The following is a description of a gene set: studied in species Homo sapiens Genes up-regulated in comparison of untreated CD4 T cells versus those treated with TGFB3, IL6 and IL32A. TGF-beta3 produced by developing Th17 cells induces highly pathogenic T cells that are functionally and molecularly distinct from TGF-beta1-induced Th17 cells. The microarray data represent a distinct molecular signature for pathogenic versus non-pathogenic Th17 cells. Human Gene Set: GSE39820_CTRL_VS_TGFBETA3_IL6_IL23A_CD4_TCELL_UP from publication Lee Y, Awasthi A, Yosef N, Quintana FJ, Xiao S, Peters A, Wu C, Kleinewietfeld M, Kunder S, Hafler DA, Sobel RA, Regev A, Kuchroo VK (PMID 22961052), and this is the list of marker genes: ATAD5, NUP160, SEC11C, RBMXL1, ZFYVE27, HOOK1, OVGP1, HNRNPAB, TNRC6A, ZNF436, ZNF638, DCAF17, REV1, KCNK10, METTL25, PALS1, WDHD1, ERCC6L (ERCC excision repair 6 like, spindle assembly checkpoint helicase), C5orf22, TCERG1, DNAJA1, OXSM, RIMOC1, ZBTB34, ERGIC1 (endoplasmic reticulum-golgi intermediate compartment 1), PLCXD2, DEK, BAG4, ZNF565, PPP2R1B, CD1D, CENPE, COX15, PTS, SF3B2 (NCBI Gene Id 170474), LGALS7, TP53BP1, FEM1B, KCTD3, LRRC40, CD83, DVL1, HAUS6, PTDSS1, XIAP, PWP1, MID1, ATP11C, TAF1D, MOSMO, KDM2B, HSPA8, NEK9, L2HGDH, RBBP4 (RB binding protein 4, chromatin remodeling factor), PUM2, CCDC77, GPATCH4, COQ2, INTS7, METTL25B, TRIM33, ESYT2, PRKCE, PPWD1, ARMC8, SLC7A6, TNIK, SESN1, PANK4, IMPACT, USP47, SLF1, ING5, CCP110, WDR44, ISG20L2, BORA, TFRC, RABGAP1L, IK, SIK3, CCNL1, MAT2A, ZNF367, AGR3, ANKRD44, SKP2, THAP2, MORF4L1, TMEM68, CCT3, AASDH, OGT, FKBP3, SACM1L, UBXN2A, PPIC, KRIT1, ZNF280D, HECA, VRK2, ADCY6, NRROS, EHD3, HSPA1A (NCBI Gene Id 3303), SEPHS1, SHPRH, PLAGL1, ZDHHC21, ZBTB5, PLK4, HSPA13, IGIP, CENPI, SCD, LSM14A, CBFB, SNHG6, HSPH1, TRIM24, INPP4B (inositol polyphosphate-4-phosphatase type II B), CCDC18, NUP107, TRMT1L, CDCA5, BLMH, ARHGAP19, MDM4, SF3B1, PKIB, RBM27, FANCF (FA complementation group F), DHX9, ZNF322, KIAA0753, TTPAL, MBNL3, ARHGEF3, FTX (FTX transcript, XIST regulator), COP1, SGMS1, EIF2S3, ST8SIA4, ABTB3, STK26, SH2D1A, DBR1, PTBP2, ARID4B, SMARCAD1, CEP70, IFITM3, TRMT10C, FYN, PPM1B, LPIN2, FAF1, FAM98B, SLC10A7, C5orf34, ABCB7 (NCBI Gene Id 8252), CDC25A, PTPN11, E2F3, ZNF644, DNMT3B, ELMO1, TEX10, SBF2, UNG, HMMR, SLFN12L, CDC40, ZDHHC17 (zinc finger DHHC-type palmitoyltransferase 17), ATAD1, POGLUT2, SETD6, DNM1L, AP1S3, SLC25A3, GPCPD1, ZNF664, MORC3, ZNF770, ASAP1, KRBA1, WDR3, ANKRD6, LRRC28, PSMD11, APOBEC1, OBI1, UBTD2, ERO1B, RFX5, NAA20, CDK17, CDC7 (cell division cycle 7), FOXN3